The following is a description of a gene set: Mouse Gene Set: GOBP_POSITIVE_REGULATION_OF_MAINTENANCE_OF_SISTER_CHROMATID_COHESION Any process that increases the extent to which the association between sister chromatids of a replicated chromosome is maintained. species: Mus musculus, and this is the list of marker genes: Bub1, Macroh2a1, Smc5, Sgo2a, Slf2, Slf1, Nsmce2